Given this list of marker genes Il6, Mecp2, Bmp4, Tgfb1, Lin28b, Stat3, here is a description of the gene set: species: Mus musculus Mouse Gene Set: GOBP_REGULATION_OF_PRIMARY_MIRNA_PROCESSING Any process that modulates the frequency, rate or extent of primary microRNA processing.